The following is a description of a gene set: electronically inferred by orthology from the curated human pathway part of: Membrane Trafficking Reactome Pathway: Rab regulation of trafficking species: Mus musculus This event has been computationally inferred from an event that has been demonstrated in another species.<p>The inference is based on the homology mapping from PANTHER. Briefly, reactions for which all involved PhysicalEntities (in input, output and catalyst) have a mapped orthologue/paralogue (for complexes at least 75% of components must have a mapping) are inferred to the other species., and this is the list of marker genes: Gdi2, Rab32, Dennd2a, Mon1a, Rab18, Gdi1, Rab33a, Rab27b, Gabarapl2, Rabgap1 (NCBI Gene Id 227800), Rab21, Dennd4b, Rab35, Tbc1d7, Ccz1, Rin1, Rab1b, Rab8b, Rab3ip, Tbc1d2, Rab39b, Rab1a, Rab10, Rab6a, Rab4a, Tbc1d24, Tbc1d15, Trappc9, Rab7, Ywhae, Rab5c, Map1lc3b, Rab9b, Rab38, Rab3a (RAB3A, member RAS oncogene family), Rabgef1, Gabarap, Sbf1, Arf6, Dennd1c, Tsc1, Ulk1 (unc-51 like kinase 1), Rab8a, Tbc1d13, Dennd5b, Dennd6a, Rab11a, Trappc5, Dennd6b, Optn, Rab39, Trappc8, Rab3gap2, Tbc1d10a, Tbc1d17, Dennd2b